The following is a description of a gene set: studied in species Homo sapiens Human Gene Set: GOMF_P_TYPE_CALCIUM_TRANSPORTER_ACTIVITY Enables the transfer of a solute or solutes from one side of a membrane to the other according to the reaction: ATP + H2O + Ca2+(in) = ADP + phosphate + Ca2+(out)., and this is the list of marker genes: ATP2A3 (ATPase sarcoplasmic/endoplasmic reticulum Ca2+ transporting 3), ATP2B3, ATP2A2, ATP2B2, ATP2B4, ATP2C2, ATP2C1 (NCBI Gene Id 612), ATP2A1, ATP2B1